The following is a description of a gene set: Genes up-regulated in bone marrow-derived dendritic cellstreated by poly(IC): 0h versus 6h. studied in species Homo sapiens Human Gene Set: GSE21033_CTRL_VS_POLYIC_STIM_DC_6H_UP from publication Olex AL, Hiltbold EM, Leng X, Fetrow JS (PMID 20682054) BACKGROUND: Dendritic cells (DC) play a central role in primary immune responses and become potent stimulators of the adaptive immune response after undergoing the critical process of maturation. Understanding the dynamics of DC maturation would provide key insights into this important process. Time course microarray experiments can provide unique insights into DC maturation dynamics. Replicate experiments are necessary to address the issues of experimental and biological variability. Statistical methods and averaging are often used to identify significant signals. Here a novel strategy for filtering of replicate time course microarray data, which identifies consistent signals between the replicates, is presented and applied to a DC time course microarray experiment. RESULTS: The temporal dynamics of DC maturation were studied by stimulating DC with poly(I:C) and following gene expression at 5 time points from 1 to 24 hours. The novel filtering strategy uses standard statistical and fold change techniques, along with the consistency of replicate temporal profiles, to identify those differentially expressed genes that were consistent in two biological replicate experiments. To address the issue of cluster reproducibility a consensus clustering method, which identifies clusters of genes whose expression varies consistently between replicates, was also developed and applied. Analysis of the resulting clusters revealed many known and novel characteristics of DC maturation, such as the up-regulation of specific immune response pathways. Intriguingly, more genes were down-regulated than up-regulated. Results identify a more comprehensive program of down-regulation, including many genes involved in protein synthesis, metabolism, and housekeeping needed for maintenance of cellular integrity and metabolism. CONCLUSIONS: The new filtering strategy emphasizes the importance of consistent and reproducible results when analyzing microarray data and utilizes consistency between replicate experiments as a criterion in both feature selection and clustering, without averaging or otherwise combining replicate data. Observation of a significant down-regulation program during DC maturation indicates that DC are preparing for cell death and provides a path to better understand the process. This new filtering strategy can be adapted for use in analyzing other large-scale time course data sets with replicates., and this is the list of marker genes: USP7, BACH1, USE1 (NCBI Gene Id 55850), ZFYVE16, UBE2D3, ZNF674, TPM4, OSR2, ETNK1, UBE3A, KIF25, SPOCK3, KCNN3, FRMD4B, EPS8L1, RABGEF1, UBA6, AMMECR1, CEP170 (NCBI Gene Id 9859), SUPT6H, MYOG, CHMP2A, NAPG, DLGAP2, NUMB, UBAP1, PIK3C3, AGFG1, SPATA6L, UBE2B, TBR1, SNIP1, SFPQ, DNTTIP2, RNF10, DDX21, USP32, PNRC1, FAM83E, PRKCZ-AS1, MXD1, LRIF1, PRLH, TUBB3, WDR37, SACS, DRD2, COPS2, PRRC2C, PPFIBP1, CDH17, ZNF143, SQSTM1, HSPA9, TNFSF14, DHCR7, BTG3, DYRK2, DCTN5, MEFV, DCP1A, ST3GAL5, MOAP1, ACSL5, RSRC1, NABP1, SMNDC1, TENT4A, MATK, TEX14, CYP11B2, PHF2, TM4SF1, CABP1, PPME1, DHX15, KHDC1L, NCS1, NUP58, PPARD, ZNF654, FASLG (NCBI Gene Id 356), SPATA2, FLT1, ATF7, C6orf15, CTRC, PLA2G4C, GATA6, SLC3A2, BCL2L11, NINJ1, IL7R, ARHGAP5, DERL1, CDV3, USP16, ZBTB43, PORCN, CD226 (CD226 molecule), ZPR1, TMEM39A, IDI2-AS1, EIF4A1, FGL1, ADAMTS7, FGF4, ZYX, GABPA, UBE2W, GUCY2F, AFF4, RNF19B, HSPB7, ANXA5, APOBR, YPEL5, ENOSF1, PRDM2, BTBD7, CD79A, SIRPA, DDIT3, TSPAN1, LEPROT, RAPGEF6, PHF10, PLAGL1, FAM3C, NR3C1, RTF2, FBRS, FCGR2C, MAGEA1, MEX3C, LAMC1, GOLT1B, ANK1, ECD, DLG4, MAGOH2P, TNFRSF1B, RPL23AP53, PICALM, SLC25A15, P2RX2, APOM, ARHGEF10, ULBP2, SLC30A6 (NCBI Gene Id 55676), PAM, GPR107, ERCC1, TOPORS, PRDM1, CMC2, CFAP70 (cilia and flagella associated protein 70), ZC2HC1C, AQP8, IL6, OR2B6, ODR4, MAD1L1, PFKFB3, ICAM5, ASH1L, NT5E, GNL1, CEP135, RXRA, SF1, SLC27A2, RHEB, NPC1, DNAJB5, AFDN-DT (NCBI Gene Id 653481), CPA4, CHMP1B, IL1R2, WDR4, B3GAT1, CMKLR1, POU6F2, ATXN3, HMG20B, AZI2, PER1, SYNJ1, FBXO28, ADNP2, PMCH, KDM6B, TMEM41B, DYRK3, ART3, NFE2L2, AKT3, GML, NSMF